Given this list of marker genes DNALI1, CPB1, ELOVL2, DNAJC12, STC2, PCSK6, RND2, CFB, ARNT2, GLRB, here is a description of the gene set: from publication Smid M, Wang Y, Zhang Y, Sieuwerts AM, Yu J, Klijn JG, Foekens JA, Martens JW (PMID 18451135) We explored whether the five previously reported molecular subtypes in breast cancer show a preference for organ-specific relapse and searched for molecular pathways involved. The intrinsic gene list describing the subtypes was used to classify 344 primary breast tumors of lymph node-negative patients. Fisher exact tests were used to determine the association between a tumor subtype and a particular site of distant relapse in these patients who only received local treatment. Modulated genes and pathways were identified in the various groups using Significance Analysis of Microarrays and Global Testing. Bone relapse patients were most abundant in the luminal subtypes but were found less than expected in the basal subtype. The reverse was true for lung and brain relapse patients with the remark that absence of lung relapse was luminal A specific. Finally, a pleura relapse, although rare, was found almost exclusively in both luminal subtypes. Many differentially expressed genes were identified, of which several were in common in a subtype and the site to which the subtype preferentially relapsed. WNT signaling was up-regulated in the basal subtype and in brain-specific relapse, and down-modulated in the luminal B subtype and in bone-specific relapse. Focal adhesion was found up-regulated in the luminal A subtype but down-regulated in lung relapse. The five major molecular subtypes in breast cancer are evidently different with regard to their ability to metastasize to distant organ(s), and share biological features and pathways with their preferred distant metastatic site. Human Gene Set: SMID_BREAST_CANCER_RELAPSE_IN_LIVER_DN species: Homo sapiens Genes down-regulated in liver relapse of breast cancer.